The following is a description of a gene set: species: Mus musculus Mouse Gene Set: GOBP_POSITIVE_REGULATION_OF_CHOLESTEROL_EFFLUX Any process that increases the frequency, rate or extent of cholesterol efflux. Cholesterol efflux is the directed movement of cholesterol, cholest-5-en-3-beta-ol, out of a cell or organelle., and this is the list of marker genes: Adipoq, Ces1c, Nr1h3, Nr1h2, Gps2, Abca12, Ces1g (NCBI Gene Id 12623), Abca8b, Pltp, Abca7, Cav1, Ces1h, Nfkb1, Abca8a, Ces1e (carboxylesterase 1E), Ptch1, Ces1f, Apoa1, Ces1b, Abca3, Abca1, Pon1, Apoe, Zdhhc8 (NCBI Gene Id 64503), Pparg, Abcg4, Ces1a, Eepd1, Ces1d, Abcg1 (ATP binding cassette subfamily G member 1), Nfkbia, Trem2, Sirt1, Lrp1